Given this list of marker genes PPARG, HOXC9, CEBPB, CEBPA, ZNF423, SMAD1, PLAC8, MPZL2, SMAD5, SMAD9, BMP4, HOXC8, HSPB7, PRDM16, ZIC1, PPARGC1B, LEP, EBF3, PPARGC1A, CEBPG, CIDEA, BMP2, BMP7, SLC7A10, ADIPOQ, here is a description of the gene set: Human Gene Set: WP_DIFFERENTIATION_OF_WHITE_AND_BROWN_ADIPOCYTE Differentiation of white and brown adipocyte species: Homo sapiens